Given this list of marker genes Zp3r, Fcgr2b, Ptpn6, C4bp, Foxp3, Cd46, Parp3, Bcl6, Cr1l, Foxj1, BC037156, Ndfip1, Cr2, Susd4, here is a description of the gene set: Mouse Gene Set: GOBP_NEGATIVE_REGULATION_OF_B_CELL_MEDIATED_IMMUNITY studied in species Mus musculus Any process that stops, prevents, or reduces the frequency, rate, or extent of B cell mediated immunity.